The following is a description of a gene set: A process leading to the generation of a functional miRNA. Includes the cleavage of stem-loop RNA precursors into microRNAs (miRNAs). miRNAs are a class of small RNAs that primarily silence genes by blocking the translation of mRNA transcripts into protein, or by increasing the degradation of non-protein-coding RNA transcripts. Human Gene Set: GOBP_MIRNA_PROCESSING studied in species Homo sapiens, and this is the list of marker genes: TRUB1 (NCBI Gene Id 170561), TGFB1, TUT4, SMAD2, DROSHA, SMAD1, RIPK1 (receptor interacting serine/threonine kinase 1), ZC3H7A, AGO2, AGO1, LIN28B, PRKRA, TRIM71, HNRNPA2B1, METTL3, HOXB-AS3, PUM2, SPOUT1, NCBP2, AGO4, SNIP1, ZMPSTE24, PUM1, BMP4, AGO3, NCBP1, LIN28A, NUP155, ZC3H7B, DGCR8, STAT3, DDX5, IL6, BCDIN3D, ADAR, SMAD3 (NCBI Gene Id 51521), TUT7, ZC3H10, TARBP2, PUS10, DICER1, TP53, SRSF3, SRRT